Given this list of marker genes CYP27B1 (NCBI Gene Id 5135), UGT1A4, CYP27A1, CYP11A1 (NCBI Gene Id 1583), FGF23, GFI1, CYP2R1, CYP3A4, NFKB1, LRP2, FGFR1 (NCBI Gene Id 84151), LGMN, SNAI2 (snail family transcriptional repressor 2), SNAI1, PIAS4, UGT1A3 (UDP glucuronosyltransferase family 1 member A3), CYP24A1, GC, IFNG, CYP1A1, TNF, here is a description of the gene set: The chemical reactions and pathways involving vitamin D, any of a group of related, fat-soluble compounds that are derived from delta-5,7 steroids and play a central role in calcium metabolism. Specific forms of vitamin D include calciferol (ergocalciferol; vitamin D2) and cholecalciferol (calciol; vitamin D3). Human Gene Set: GOBP_VITAMIN_D_METABOLIC_PROCESS studied in species Homo sapiens